Given this list of marker genes CDK6, ANAPC10, SKP2, CCND2, CCNE1, ANAPC2, CCNE2, CDK4, ANAPC15, ATRX, UBE2E1, CDK2, CDKN1A, E2F2, ANAPC4, ANAPC16, ANAPC5, UBE2C, DAXX, UBE2S, RB1, CDC16, ANAPC7, E2F3, CDKN1C, CCND1, TFDP1, CDC23, CDC26 (NCBI Gene Id 246184), ANAPC1, TFDP2, CDKN1B, FZR1, UBE2D1, E2F1, ANAPC11, CDC27, CCND3, here is a description of the gene set: Diseases of mitotic cell cycle are caused by mutations in cell cycle regulators, such as retinoblastoma protein RB1, as well as proteins involved in telomere maintenance, such as ATRX and DAXX. These diseases mainly include different types of cancer, hereditary syndromes such as dyskeratosis congenita that may predispose affected patients to cancer, and neurodegenerative diseases. Reactome Pathway: Diseases of mitotic cell cycle part of: Disease species: Homo sapiens